The following is a description of a gene set: Any abnormality of the fifth metacarpal bone. species: Homo sapiens Human Gene Set: HP_ABNORMAL_5TH_METACARPAL_MORPHOLOGY Abnormal 5th metacarpal morphology, and this is the list of marker genes: BMP2, FLNA, SRCAP, ERI1, PRKG2, SMOC1, LTBP3, HOXD13, FGF16, CSPP1 (centrosome and spindle pole associated protein 1), NOG, EIF4A3, RUNX2, LBR, SMC3, GNAS, FBN1, TBX3, SVBP, FERMT1, KIAA0586, COL11A2